Given this list of marker genes RPUSD1, PUS10, RPUSD2, RPUSD3, PUS7, PUSL1, TRUB2, RPUSD4, PUS7L, DKC1, TRUB1, PUS3, PUS1, here is a description of the gene set: studied in species Homo sapiens Catalysis of the reaction: a uridine in RNA = a pseudouridine in RNA. Conversion of uridine in an RNA molecule to pseudouridine by rotation of the C1'-N-1 glycosidic bond of uridine in RNA to a C1'-C5. Human Gene Set: GOMF_PSEUDOURIDINE_SYNTHASE_ACTIVITY